The following is a description of a gene set: Binding to small ribosomal subunit RNA (SSU rRNA), a constituent of the small ribosomal subunit. In S. cerevisiae, this is the 18S rRNA. species: Mus musculus Mouse Gene Set: GOMF_SMALL_RIBOSOMAL_SUBUNIT_RRNA_BINDING, and this is the list of marker genes: Mrps6, Mrps18a (NCBI Gene Id 98069), Rps13, Rps3, Utp23, Cirbp, Nsun4, Map3k20, Mrps18c